The following is a description of a gene set: species: Mus musculus part of: Intracellular signaling by second messengers electronically inferred by orthology from the curated human pathway Reactome Pathway: PIP3 activates AKT signaling This event has been computationally inferred from an event that has been demonstrated in another species.<p>The inference is based on the homology mapping from PANTHER. Briefly, reactions for which all involved PhysicalEntities (in input, output and catalyst) have a mapped orthologue/paralogue (for complexes at least 75% of components must have a mapping) are inferred to the other species., and this is the list of marker genes: Phlpp1, Psma6, Cdkn1a, Grb2, Cbx6, Kl, Vav1, Trat1, Lamtor1, Fgf2, Pip4k2c, Gab1, Psma7, Irs1, Egfr, Fgf7, Rictor, Ppp2r5b, Phc1, Pdgfrb, Cd80, Psmb6, Irs2, Lck, Psmc2, Psma5, Rraga, Psma3, Psmb4, Rnf146, Phlpp2, Mbd3, Frs2, Psma1, Ier3, Lamtor4, Erbb2, Psmc4, Nrg3, Pik3cb, Cd28, Myd88, Mapk3, Klb, Hgf, Ins2 (insulin II), Fgf16, Il1rl1, Pik3r2, Rbbp7, Rragc, Btc, Lamtor5, Ppp2r5a, Psmd13, Akt1s1, Foxo4, Epgn, Il33, Wwp2, Cbx2, Ntf5, Tgfa, Tnks2, Rbbp4, Sgk1 (serum/glucocorticoid regulated kinase 1), Cdkn1b, Pdgfa, Cbx8, Psmd6, Psmd7 (proteasome (prosome, macropain) 26S subunit, non-ATPase, 7), Ins1, Fgf4, Erbb4, Psmd12, Psmd1, Psma4, Areg, Nr4a1, Strn, Kit, Rheb, Otud3, Ubb, Psmb5 (proteasome (prosome, macropain) subunit, beta type 5), Mta1, Fgfr1, Psmc3, Them4, Kitl, Rps27a (NCBI Gene Id 78294), Psmc6, Pdpk1, Fgf6, Casp9, Fgf1, Psma2, Pip5k1c, Scmh1, Cbx4, Sall4, Rac2, Foxo6 (NCBI Gene Id 329934), Fgf8, Icos, Ezh2, Fgf20, Maf1, Ppp2r1b, Esr1, Fyn, Bmi1, Cd19, Rps6kb2, Lamtor2, Mta2, Trim27, Ring1, Pik3ap1, Irak1, Fgf5, Psmb7, Psmc5, Bdnf, Fgf15, Fgf17, Fgf23, Pik3r5, Ppp2r5d, Pdgfb, Psmc1, Fgf10, Pip5k1a (phosphatidylinositol-4-phosphate 5-kinase, type 1 alpha), Fgf22, Flt3l, Esr2, Csnk2b